Given this list of marker genes LAMA3, CXCL12, LAMA1, MDK, PTK2 (NCBI Gene Id 5747), RHOA, PRKCA, FGF2, FN1, THBS1, TNFRSF13B, CXCR4, TNC (NCBI Gene Id 3371, tenascin C), PRKCD, FGF6, MMP9, DNM2, ITGB1, FGFR1, TFPI, NUDT16L1, SDC4, FZD7, ADAM12, ACTN1, F2, RAC1, PLG, CCL5, SDCBP (NCBI Gene Id 6386), GIPC1, ITGA5, here is a description of the gene set: Human Gene Set: PID_SYNDECAN_4_PATHWAY species: Homo sapiens Syndecan-4-mediated signaling events from publication Schaefer CF, Anthony K, Krupa S, Buchoff J, Day M, Hannay T, Buetow KH (PMID 18832364)